The following is a description of a gene set: from publication Tenedini E, Fagioli ME, Vianelli N, Tazzari PL, Ricci F, Tagliafico E, Ricci P, Gugliotta L, Martinelli G, Tura S, Baccarani M, Ferrari S, Catani L (PMID 15271793) Genes essential to the development of megakaryocytes, as expressed in normal cells and essential thrombocythemic cells (ET). Human Gene Set: TENEDINI_MEGAKARYOCYTE_MARKERS Gene expression profiles of bone marrow (BM) CD34-derived megakaryocytic cells (MKs) were compared in patients with essential thrombocythemia (ET) and healthy subjects using oligonucleotide microarray analysis to identify differentially expressed genes and disease-specific transcripts. We found that proapoptotic genes such as BAX, BNIP3, and BNIP3L were down-regulated in ET MKs together with genes that are components of the mitochondrial permeability transition pore complex, a system with a pivotal role in apoptosis. Conversely, antiapoptotic genes such as IGF1-R and CFLAR were up-regulated in the malignant cells, as was the SDF1 gene, which favors cell survival. On the basis of the array results, we characterized apoptosis of normal and ET MKs by time-course evaluation of annexin-V and sub-G1 peak DNA stainings of immature and mature MKs after culture in serum-free medium with an optimal thrombopoietin concentration, and annexin-V-positive MKs only, with decreasing thrombopoietin concentrations. ET MKs were more resistant to apoptosis than their normal counterparts. We conclude that imbalance between proliferation and apoptosis seems to be an important step in malignant ET megakaryocytopoiesis. species: Homo sapiens, and this is the list of marker genes: CASP3, IL11, KIT, STAT1, IL1R1, MECOM, STAT3, CCND3, GP6, PF4, CCNB1, RASA1, CCL5, FOS, PIK3C2B, MAPK14, IL6R, MAFG, IL11RA, PDGFA, BAD, FLI1, ITGA2B, PDGFC, GATA1, CBFA2T3, CDK1, RASGRP2, PDGFB, JUND, PPBP, CDKN1B, JAK2, CCNE1, BCL2L2, IL6, CASP9 (caspase 9), JARID2, IL1B, MYB, TAL1, CCNE2, TGFB1 (transforming growth factor beta 1), ITGB3, CXCL1, VEGFA, BCL2, CBFA2T2, CD9, GP9, NFE2, CXCL8, IL3RA, MCL1, MYC, CDKN2A, CXCR4, BAK1, STAT5A, CDK2 (cyclin dependent kinase 2), GP1BA, MPL